The following is a description of a gene set: Active suppression of tumor-specific T lymphocytes can limit the immune-surveillance and immunotherapy efficacy. While tumor-recruited CD11b+ myeloid cells are known mediators of tumor-associated immune dysfunction, the true nature of these suppressive cells and the fine biochemical pathways governing their immunosuppressive activity remain elusive. Here we describe a population of circulating CD11b+/IL-4Rα+, inflammatory-type monocytes that is elicited by growing tumors and activated by IFN-γ released from T lymphocytes. CD11b+/IL-4Rα+ cells produce IL-13 and IFN-γ and integrate the downstream signals of these cytokines to trigger the molecular pathways suppressing antigen-activated CD8+ T lymphocytes. Analogous immunosuppressive circuits are active in CD11b+ cells present within the tumor microenvironment. These suppressor cells challenge the current idea that tumor-conditioned immunosuppressive monocytes/macrophages are alternatively activated. Moreover, our data show how the inflammatory response elicited by tumors has detrimental effects on the adaptive immune system and suggest novel approaches for the treatment of tumorinduced immune dysfunctions. species: Homo sapiens Genes up-regulated in ITGAM+ cells (incubated for 24h in complete medium) from spleen: healthy versus tumor bearing mice. Human Gene Set: GSE5455_HEALTHY_VS_TUMOR_BEARING_MOUSE_SPLEEN_MONOCYTE_24H_INCUBATION_UP from publication Gallina G, Dolcetti L, Serafini P, De Santo C, Marigo I, Colombo MP, Basso G, Brombacher F, Borrello I, Zanovello P, Bicciato S, Bronte V (PMID 17016559), and this is the list of marker genes: REEP1, TTYH3, PALS1, BRME1, PSD3, MTG1, HP1BP3, ZFP69, GUCY1A1, DLG1, PNISR, GOLPH3L, RBM4B, P4HA2, ZNF879, MAGEF1 (MAGE family member F1), FRY, PYROXD2 (NCBI Gene Id 84795), FGGY, TDO2, SLC25A37, DRC1, TSPAN9, ARMC7, SLC29A2 (solute carrier family 29 member 2), COL23A1, TMEM269, RFX2, CCDC14, EXD1, SLC25A27, NICN1, RCN1, BCDIN3D, TMED8, ZFC3H1, ZDHHC16 (zinc finger DHHC-type palmitoyltransferase 16), RNF32, RCAN3, PANK3, EXPH5, FGFBP3, PRRG1, SNHG7, FBXL4, STX1A, SUPT7L, TBC1D16, CLIC5, FAM118A, MOCS2 (NCBI Gene Id 4338), ZNF329, DENND2C, NLRP6, PTPN21, ASH1L, TLE4, CZIB, GPRASP2, RO60, TBC1D19, TUBB2B, ABCB11, DENND11, DDX19B, ABHD14B, GINM1, ABCB6, HSD17B7 (NCBI Gene Id 63064), DNASE1L1, NPC2, MFSD3, PDPR, NDRG1, RSBN1, TMEM258, ACOXL, KRT1 (keratin 1), GET1, SUN1, F2RL1, PADI1, BOLL, NFE2L2, BACH1, FNBP1L, PTS, MYLIP, GDA, RPS6KB1 (NCBI Gene Id 6796), PNCK, SENP8, SPATS2L, NIPAL1, SH3YL1, DRC3, LAMA3, CDC42BPG, CPSF6, VAMP1, SHE, TRIB3, ADAT1, MRAP, SLC30A7, PDE2A, RWDD2A, BFSP2, ATN1, ACP3, NGRN (NCBI Gene Id 51335), DMBT1, TPST1, SORCS2, GLUL, UHMK1, OSGIN1, LRRC75B, TEC, ATG4C, JUP, CAP2, SLC16A7, TANC2, SPMIP7, MSL1, MTCP1, TNPO2, ITGB3, PATZ1, OLIG1, TAFA3, RERE, NIN, HOXA1, ARMC9, FOXRED2 (FAD dependent oxidoreductase domain containing 2), VPS13C, VWA7, SLC16A10, N4BP2, TUBB2A, ZNF397, MLLT11, HID1, TBXA2R, WTAP, MMP11, WDR48, ZNF629, PLAUR, VANGL2, HOXD4, SFRP2, ABLIM1, TESK2, PSTPIP2, PTK2, PADI3, KCTD6, COL11A2, NSMCE1, BRMS1L, KAZALD1, MYO5B, IRAG1, HAUS1, BMP5, ARHGEF33, WNT5B, IGF2R, URGCP, TENT5A, PADI2, AFF2, BBS7 (Bardet-Biedl syndrome 7), BBS9, SMUG1, NDUFB11, HCFC2, ZNF764, SELENBP1, ABO, PRRT1, GDPD1, HIF1AN, FAM120AOS, SEMA4A, RABGAP1L, ZFYVE21, ACTN2, ERAL1, DTX4, SPICE1, TMCC3, LCA5 (NCBI Gene Id 30828), ZMYND12, PRKD3, KRT10